The following is a description of a gene set: The Human Phenotype Ontology provides terms to describe specific phenotypic abnormalities rather than disease diagnoses. Nevertheless, it is common for descriptions such as 'Autism' to be used to describe individuals affected with Mendelian forms of neurodevelopmental disease and many other conditions. If possible, we recommend annotation using specific terms in other branchs of the Atypical behavior subontology, but if this is not possible, then terms from this branch may be used. Diagnostic behavioral phenotype Human Gene Set: HP_DIAGNOSTIC_BEHAVIORAL_PHENOTYPE studied in species Homo sapiens, and this is the list of marker genes: ATP6V1A, GRIA1, ALG13, GABRB3, SMC3, USH1C, SVBP, VPS35, FBXW11, ZIC1, CLRN1, FERRY3, NMNAT1, DNM1, ALG14, KCNC2, MED13L, NEXMIF, RAD21, PRRT2, LRRK2 (NCBI Gene Id 399472), CACNA2D1, WWOX, TCF12, CYP27A1, SLC25A22, MAOA, TPM2, BICRA, MT-TF, SCN1B, FRRS1L, FLCN, TAF1, SIK1, SKI (SKI proto-oncogene), NEUROG1, USP7, MAGEL2, ALDH5A1, ATG7, CUL3, TRAK1, SBF2, TMEM216, DALRD3, ARX, TRIP12, LCA5, BBS7, MT-TQ, SYNGAP1, GUCY2D, CELF2, FGF13, MT-TH, TTC5, RD3, HECW2, CAPRIN1, H3-3A, SLC35A3, APOL2, SIN3A, MT-TE, MKKS, KPTN, ASXL3, AP1G1, GATAD2B, TMEM237, GLYCTK, TCEAL1, RTN4R, CLIP2, FA2H, NEUROD2, MFSD2A, CAPN15, NF1, POMT1, IFT74, SCAPER, ARID1A, STEEP1, PIGG, SCN9A, KCNJ13, KDM6B, TCF20, KRT86, WARS1, USP45, CEP19, JARID2, RORA, SMARCE1, NIPA2, AMACR, SOX3, ALAD, SETD5, GRIA3, PIGO, DYRK1A, IL1RAPL1, PTEN, TBL1XR1, CHKA, DNMT3A, IQSEC2, PWRN1, CHD8, HIVEP2, NDN, SCAF4, KRT83 (NCBI Gene Id 652010), CHD3, TOGARAM1, PCGF2, TMLHE, DAOA, KRT81, DMPK, TCF4, SMPD1, UBE3A, PPP3CA, SPATA7, GABBR1, DCX (doublecortin), BRD4, KLLN, SCN3A, ARSG, PSAP, NFIB, IQCB1, TAF4, BAP1, HCN1, PUF60 (poly(U) binding splicing factor 60), SETD2, PPP2R5D, SLF2 (NCBI Gene Id 55719), MAPK8IP3, CCNK, RNU4-2 (RNA, U4 small nuclear 2), USH2A, TOE1, CTCF, PDPN, CDC42BPB, RPS23, NHS, TBR1, GDF6, MT-ND5, THOC2, POLR2A, ARID2, CEP85L, KANSL1, MT-CO2, RDH12, MAX (MYC associated factor X), PACS1 (phosphofurin acidic cluster sorting protein 1), POU4F1, TSC2, ARCN1, AGO1, SZT2, HNRNPH2 (NCBI Gene Id 3188), NR4A2, SNX14, KDM3B, CDH15, DPYS (NCBI Gene Id 1807), HDAC4, KMT2C, MAP1B, TMEM222, GNAQ, LRAT, ATP1A1, NPRL2, HEXB, STS, BCOR, CHD7, PSMC3 (proteasome 26S subunit, ATPase 3), KMT2A, CACNA1B, RAB39B, ZBTB7A (zinc finger and BTB domain containing 7A), NPRL3, SETD1A, SMAD4, SCN8A, ADH5, COMT, ZNF711, ARSA, HNF1B, TLK2, PPM1D, CASZ1, ZNF423, EFL1 (NCBI Gene Id 79631), METTL27, SMC1A, PRORP (NCBI Gene Id 9692), WDPCP, EXT2, LIMK1, ATRX, PIGP, KDM6A, MBOAT7, CEP78, UFD1, RFX7, TUBB4B, PRR12, CACNA1A, IFT172, CDK8, CAMTA1, EEF1A2, POLG, SRP54, HSPG2, SOX2, ACBD6, REV3L, FOXP1, MT-ND6, SRCAP, ZNFX1, FBXO11, TAOK1, HDAC8, SDCCAG8, PCDH15, GRM7, POLA1, RAC1, SLC12A2, KMT2D, SRY, FRA10AC1, RRM2B, NTNG1, BBS4, FMR1, RPGRIP1 (RPGR interacting protein 1), GABRD, AGO2, FGF12, CHD5, NLGN1, SNRPN, MCTP2, PDE4D, SMARCC2, SNORD116-1, ANKRD17, ALDH4A1, ARL6, RPS6KA3, CASK, DDX3X, SYN1, CAMK2B, H4C11, DSG4 (desmoglein 4), GABRA2, NFIX, RLIM, FTSJ1, CHD1 (chromodomain helicase DNA binding protein 1), PAH, CDH2, WAC, GTF2IRD2, PIGA (NCBI Gene Id 5277), GTF2I, TMEM270, RSPRY1, SBDS, MTSS2, KAT8, IFT140, ZNF292, CDK13, DEAF1, RAI1, BAZ1B, H4C5, UBAP2L, SCLT1, ASH1L, U2AF2 (NCBI Gene Id 11338), GRIN2A, SON, KCNH5, ATP1A2, SPEN, DLL1, ZFX, RSRC1, GALNT2, DPYSL5, GAMT, PRKAR1B, ZMYM3, MT-ND4, FBXO28, FTCD, ATP6V1B2, DLK1, CHRNA7, BBS2, NTNG2, BBS9, ARNT2, AFF3, GRIN2D, ZMYM2, FOSL2, VPS16, SCN1A, SYN2 (NCBI Gene Id 6854), OPHN1, DLG4, IFNG, USP9X (NCBI Gene Id 8239), POGZ, NOVA2, FLI1, SLC38A3, AP3B2, CNTNAP2, MED13, NSUN2, CC2D2A, SMARCA2, MSTO1, HTR2A, GCSH, SYNJ1, CIB2, TNPO2, CNKSR2 (connector enhancer of kinase suppressor of Ras 2), RNF135, ZSWIM6, FLG, NIPBL, PIGY, MED12, GJA8, DOCK7, TBX2, PROKR2, LUZP1, KDM5A, SNCA, MADD, FOXP2 (forkhead box P2), WFS1, CLCN4, DICER1, EIF5A, SDHC, SYT1, GNAO1, PPP2CA, IFT27, RREB1, PIGL, SLC6A8, HARS1, NAA10, MID1, SOX11, JAM2, BCL11A, PARS2, UBE4B, NAA20, SMARCB1, VAMP2, TRIM8, YY1, NDP, DNAJC21, VPS13B, AP1S2, TNRC6B, NIPA1, APOL4, NECAP1, BBIP1 (BBSome interacting protein 1), ZFPM2, AP2M1, AIPL1, ATP9A, JAG2, TM4SF20, CDKL5, OCA2, MYO7A, UBTF, SEC24C, MT-TS2, EP300, GRIA2, BBS5, GABBR2, CFAP418, DNAJC13, TBX1, GP1BB (NCBI Gene Id 89199), GRIK2, AUTS2, CHD2, SOX4, SLC35C1, NSUN6, SH2B1, BCORL1, USF3, ERI1, STAG1, SDHD, DRD3 (NCBI Gene Id 2111), ACSL4, CNOT3, TANC2, NPAP1, KAT6A, RTL1, RALA, ANKRD11, SATB2, STXBP1, ABCB7, STX1B, HEPACAM, OTX2, AARS1, PLXND1, IARS1, CREBBP, RFC2, NAA15, LZTFL1, BBS1, CRX, EIF4A2, OTUD6B, GRIN1, SPTBN1 (spectrin beta, non-erythrocytic 1), FZR1, CACNA1C, MMP23B, PDZD8, EIF4H, PIGS, CTNNB1, VPS37D, PRODH, ARID1B, HERC2, PCDH19, DEPDC5, NUS1, NBEA, SETD1B, TULP1, PSMD12, MED12L, ZMIZ1, SLC9A6, ALMS1, GNAI1, PIGQ, CAT, SUPT16H, MTHFR, PCYT1A, ADGRV1, MT-CO1, ACTL6B, GIGYF2, JMJD1C, SLC1A2, GABRA5, SEMA3E (NCBI Gene Id 9723), RERE, BBS10, NONO, HECTD4, PHACTR1, SEC23B, SRRM2, MEIS2, ATP1A3, DPF2, CRB1, NLGN3, GJA5, ZDHHC9, GTF2IRD1, KDM5C, SLC32A1, PRDM16, GABRB2, FGFR1, SOX6, SCN2A, INTS1, TIAM1, STX1A, KMT5B, SNORD115-1, TAF6, TFE3, SLC6A1, CTNNA2, DHCR7, TMEM138, NKX2-1, KCNAB2, MT-TL1, POLG2, DPAGT1, ALDH18A1, DPP9, UBE3C, TRRAP, SIM1, MAPK10, TUBG1, PRKCZ, SDHB, NSD1, OTUD5, CDH11 (NCBI Gene Id 1009), FRMPD4, GNB2, APC2 (NCBI Gene Id 10297), TMEM231 (transmembrane protein 231), METTL5, MTOR, PAK2, ARVCF, TRIO (trio Rho guanine nucleotide exchange factor), AFF2, BBS12, DMXL2, KDM4B, TBCK, RPE65, KMT2B, SATB1, ADNP, TRAF7, USH1G, GATM, WBP4, CLN8, PIGV, IMPDH1, AFG2A, ESPN, UBA2, ELN, CBS, FOXG1, CARS2, DOLK (dolichol kinase), ZBTB20, ATP2B1, CASP2, KCNA2 (potassium voltage-gated channel subfamily A member 2), SIN3B, MEG3, DPYD, SMARCA4, GABRG2, GALT, SETBP1, SLC13A5, PDGFRB, ANK3, BCKDK, SPTAN1, ADSL, MT-CO3, MKS1, FKBP6, TMTC3, RPGRIP1L, WHRN, CIC, NCAPD2, UBA5, GBA1, DNAJC30, STAG2, KCNB1, ASCC3, DDC, PACS2, SHANK3, TBL2, AHDC1, ZNF462, TSC1, MAN1B1, COG5, KCNN2, TTC8, NPHP1, MT-TW, PHF21A, PGAP2, CLCN3, DHDDS, ATP2A2, BCL11B, TRPM3, TRIM32 (NCBI Gene Id 3971), LHX1, TWNK, TBC1D23, PNKP, NCF1, HESX1, TBC1D2B, HIRA, LSS, PDZD7, PTCHD1, MBD5, GLRA2, EIF4G1, MYT1L, CDH23, PGAP3, ATP6V0A1, RIMS2, SMARCD1, NTRK2, EHMT1, POU3F3, SPECC1L, CEP290, DHX30, FBLN5, CLTC, CHI3L1, CYFIP2, UPF3B, MEF2C, YWHAG, NR2F1, RPL10, SLITRK2, UBE4A, TET3, BUD23, PLCB4, QRICH1, GNB1, PLA2G6, RBM12, AKT1, PIGW, SLC25A4, NAGA, PIK3CA, MECP2, SLC2A1, CUX2, TBC1D24, PWAR1, CDK19, PLXNA1, ADGRL1 (NCBI Gene Id 79732), MKRN3, GABRA1, KCNA1, NLGN4X, MT-ND1, NSD2, WDR26